The following is a description of a gene set: T cell dysfunction is an important feature of many chronic viral infections. In particular, it was shown that PD-1 regulates T cell dysfunction during chronic LCMV infection in mice and PD-1 high cells exhibit an intense exhausted gene signature. These findings were extended to human chronic infections such as HIV, HCV and HBV. However, it is not known if PD-1 high cells of healthy humans have the traits of exhausted cells. In this study, we provide a comprehensive description of phenotype, function and gene expression profiles of PD-1 high versus PD-1 low CD8 T cells in the peripheral blood of healthy human adults as following: 1) The percentage of naive and memory CD8 T cells varied widely in the peripheral blood cells of healthy humans and PD-1 was expressed by the memory CD8 T cells. 2) PD-1 high CD8 T cells in healthy humans did not significantly correlated with the PD-1 high exhausted gene signature of HIV specific human CD8 T cells or chronic LCMV specific CD8 T cells from mice. 3) PD-1 expression did not directly affect the ability of CD8 T cells to secrete cytokines in healthy adults. 4) PD-1 was expressed by the effector memory (TEM) compared to ‘terminally differentiated effector’ (TEMRA) CD8 T cells. 5) Finally, an interesting inverse relationship between CD45RA and PD-1 expression was observed. from publication Duraiswamy J, Ibegbu CC, Masopust D, Miller JD, Araki K, Doho GH, Tata P, Gupta S, Zilliox MJ, Nakaya HI, Pulendran B, Haining WN, Freeman GJ, Ahmed R (PMID 21383243) Human Gene Set: GSE26495_NAIVE_VS_PD1HIGH_CD8_TCELL_UP Genes up-regulated in comparison of naive CD8 T cells versus PD-1 high CD8 T cells. studied in species Homo sapiens, and this is the list of marker genes: SERP1, NT5E, SREBF1, FBXO15, MMEL1, TXNRD3, KLHL6, SPART, EFNA1, LEF1, FBLN2, MAL, BEND5, PRRT1, USP51, ATG9B, ROBO3, ZNF667-AS1, SALL2, TRABD2A, ADGRA3, CA6, SNHG32, PRKCQ-AS1, ZBTB18 (zinc finger and BTB domain containing 18), CHMP7, GPRASP2 (G protein-coupled receptor associated sorting protein 2), ZNF496, SH3RF3, AGBL2, DCHS1, MAN1C1, ZNF285, BEX3 (brain expressed X-linked 3), CEP170, TKTL1, IL6R, SPEG, LRRN3, SNED1, TAF4B, SELL, MAML2, TNFRSF10D, EIF2D, C17orf67, TSEN2, NR3C2, AK5, CBR3, KLF7, SPEN-AS1, IGF1R, PKIG, IPCEF1, SPINT2, HAPLN3, NAT9, GP5, CYP2J2, TBXA2R, ZNF662, UBIAD1, USP6NL, SLC16A10, RNF157, MCF2L-AS1, NUDT9P1, ARHGEF4, GFOD3P, NREP, ZBTB10, HPCAL4, GNG7 (NCBI Gene Id 90274), CD248, NDFIP1, SUSD3, FLNB, AZIN2, ACSS2, THEM4, LEF1-AS1, RHPN2, PDK1, ITGA6, PRXL2A, CATSPERE, PIK3IP1, CLEC11A, UBQLN2 (NCBI Gene Id 29978), HSBP1L1, SOX8, EPHA1-AS1, ADPRM, GAL3ST4, RFX2, IL6ST, FBP1 (NCBI Gene Id 2203), BDH1, SH3YL1, DSC1, PLPP1, OXNAD1, BPHL, MYB, CEP41, PRKCA, SCOC-AS1, SCML2, SCML1, FAM216A (family with sequence similarity 216 member A), PABPC3, MICU3, FOXP1, FAM117B, TOP1MT, SFXN4, ENSG00000280119, EFHC2, PCSK5, TCF3, REG4, SULT1B1, CAPN5 (calpain 5), CHCHD7, GIPC3, LMF1, PKIA (cAMP-dependent protein kinase inhibitor alpha), ACTN1, FOXO1, PDCD4-AS1 (NCBI Gene Id 282997), SPINK2, TMEM220, OVGP1, RAB43, CCR7, MRRF, EFHD1, CLN5 (NCBI Gene Id 1203), EPB41L2, CNKSR2, TCEAL3, RNF175, NRCAM, OBSCN, TECPR1, MDS2, PDE9A, STXBP1, SLC7A3, ECRG4, CNKSR1, APBB1, SARAF, LDLRAP1 (low density lipoprotein receptor adaptor protein 1), EDAR, RBM26-AS1, TMEM272, C3orf18, NELL2, STRADB, SLC22A17, UBE2E2, RETREG1, AEBP1, ZNF436-AS1, CT75, AMIGO1, VIPR1, AGMAT, IRS1, PLEKHG4, DENND5A, TPST1, SFXN5, PLAG1, LINS1, NEXMIF, KRTCAP3, YPEL2, CD55, CLTRN, EPHA1, FAM184A, CARS1, ARMCX1, PASK (NCBI Gene Id 26144), NAA16, C19orf18, NOG, MEST, ZNF93, ATP6V0E2-AS1